The following is a description of a gene set: The directed movement of RNA to a specific location. studied in species Mus musculus Mouse Gene Set: GOBP_ESTABLISHMENT_OF_RNA_LOCALIZATION, and this is the list of marker genes: Ythdc1, Kpnb1, Alyreffm9, Ddx39b, Sidt2, Peg10, Nup153, Pom121 (nuclear pore membrane protein 121), Eif4e, Alyreffm6, Snupn, Cetn3, Casc3, Pom121l2, Nup58, Tgfbr2, Mrpl18, Nxf2, Atm, Nup210, Rftn1, Tomm20l, Ranbp17, Nup35, Alyreffm10, Ddx39a, Seh1l, Alyreffm1, Nup50, Fxr2, Zc3h11a, Thoc6, Nup62, Nxf3, Wnk1, Pcid2, Alyreffm14, Nxt2, 1700017N19Rik, Dhx9, Srsf3, Zfp36, Alkbh5, Tomm20, Gle1 (GLE1 RNA export mediator), Ybx1, Hnrnpa1, Htt, Sec13, Alyref2, Nxf1, Alyreffm7, Mapt, Sidt1, Arc, Thoc2, Cetn2, Nup160, Cpsf6, Nup133, Sem1, Nup62cl, Ddx25, Terf1, Nxf7, Rbm15b (NCBI Gene Id 76348), Ndc1, Nup107, Tpr, Ddx19a, Rbm33, Fmr1, Xpo1, Ssb, Igf2bp3, Pnpt1, Nup85, G3bp2, Hnrnpa2b1, Alyreffm2, Ranbp2, Flot1, Igf2bp1, Ncbp1, Senp2, Thoc7, Poldip3, Lrpprc, Aaas, Igf2bp2, Iws1, Nup37 (NCBI Gene Id 72714), Pabpn1, Nup93, Alyref, Phax, Alyreffm5, Ckap5, Srsf7, Hhex, Thoc3, Magoh, Eif4a3, Magohb, Atr, Hnrnpa3, Nrde2, Nup188, Alyreffm11, Thoc5, Ncbp3, Parp11, Slbp, Nup88, Alyreffm3, Ahctf1, Qki, Alyreffm8, Nup42, Supt6, Hsf1, Nutf2, Nup155, Eny2, Bicd2, Nxt1, Rbm8a, Alyreffm4, Ddx19b, Thoc1, Nup214, Nsun2, Xpot, Fyttd1, Zc3h3 (NCBI Gene Id 245129), Nup43, Srsf1, Nup98 (NCBI Gene Id 330609), Kif5c, Khsrp, Akap8l, Rftn2, Ran, Sarnp, Nup54, Rae1, Tst, Thoc2l, Chtop (chromatin target of PRMT1), Zfp36l1, Setd2, Tnks, Xpo5, Nol6, Cpeb1, Fxr1, Khdrbs1, Ncbp2, Mcm3ap